Given this list of marker genes Dck, Srsf3, Ifi213, Paqr5, Tpm4, Trim12c, Coro1a, Bcl11a, Phf11b, Sct, Mrfap1, Ifi27l2a, S100a6, Fads3, Samhd1, Isg20, Epsti1, Cbx5, Parp14, Arf4 (NCBI Gene Id 30916), Mvd, Scarb2, Clec2d, Micos10, Slc31a1, Tubb4b, Chordc1, Ifi209, Ptpn6, Bbx, Hck, Exosc3, Ubxn4, Ldlr, Armcx3, Rbm3, Dusp28 (dual specificity phosphatase 28), Tapbpl, Ctsc, Rngtt (RNA guanylyltransferase and 5'-phosphatase), Oasl1, Sec23b, Grn, Tapbp, Mndal, Nt5c3, Ncf1 (neutrophil cytosolic factor 1), Fdft1 (farnesyl diphosphate farnesyl transferase 1), Ly6d, Ifitm3, Nfkbid, Ly86, Ifi47, Bcl7c, Irgm2, Psma5, Nlrc5, Aida, Tor1aip2, Eif1, Or2l13, Msn, Cotl1, H2-T23, Psma7, Phf11a, Nfkbie, Pkib, Cd69, Cyp51, Dnajb1, Tmbim6, Zc3h7a, Lgmn, H2-T22, Ptms, Gramd2b, Calhm6, Helz2, Ssr1, Sgcb, Ppia, Treml2, 9930111J21Rik2, Evi2a, Irf1, Rnh1, Sco1 (NCBI Gene Id 67104), Gbp8, Dclre1c, Pttg1, Tap2, Psma3, Rasa4, Arhgef10l, Hnrnpa3, Parp12 (poly (ADP-ribose) polymerase family, member 12), Prelid3b, Ms4a6c, Glipr1, B2m, Kif5b, Psma4, Bst2, Ifi204 (interferon activated gene 204), Hivep3, Jaml, Galk1 (galactokinase 1), Insig1, Lgals3bp, Psmb9, M6pr, Trafd1, Arf1, Grb2, Spns1, Dynll1, Map2k1, Dnaja1, Plac8, Tmod3, Psme1, Necap2, Sdhb, Sri, Vcpip1, Plaat3, Idi1, Tmsb10, Sp140, Gbp7, Fdps, Pdzd8, Carmil1, Stau2, Ddx60, Pdia3, Hsp90aa1, Plin2, Rell1, Il2rg, Edem1, Eif4g2, Ctsz, Trp53i11, Smim5, Marchf5, Klk1, Hspd1, Mgat1, Psmb6, Npc2, Stip1, Prkcd, Slc35b1, Sla2, Chmp4b, Pml, Nsg2, Ascc3, Nfkb2, Trim30d, Orai3, Etnk1, Cmpk2, Cd52 (NCBI Gene Id 23833), Vdac2, Wdr45b, Gabarap, Dek, Selplg, Tcstv4, Selenow, Slc2a6, Psmb2, Trim30b, Iigp1, Calr, Hsp90b1, Zmiz2, Fnbp4, Procr, Mif4gd, Il21r, Usp18, Sar1a, Gng12, Dynll2, Ifi44, Actr2, Spib, Sec22b, Taldo1, Derl2, Ptges3, Actr3, Srsf5, Gmppb, Ndufa11, Ogfr, Ddx39a, Tmem248, Nampt, Ube2n, Znfx1, Cpne3, Cybc1, Map3k8, Napsa, Nfam1, Sumo1, Anxa4, Nudcd3, Sp100, Zcchc24, Ankrd12, Dnajc3, Oas3, Tor1aip1, Txn1, St13, Manf, Daxx, Esyt1, BC005537, Pmepa1, Pdlim1, Mfsd12 (NCBI Gene Id 73822), Xbp1, Cct3, Xaf1, Klrk1, Zfand3, Ccnd3, Zbp1, Serpina3g, Gtf3c6, Hmgn3, Hspa5, Irf7, Sub1, Emc8, Ndufb6, Psme2, Ergic1, Atp6v1g1, H2-K1, Mpc1, Tlr7, Ccr9, Rftn1, Themis2 (NCBI Gene Id 230787), Ppp1r11, Phyh, Lrp8, Gadd45b, Herc6, Ifit1, Reep3, Isg15, Cacybp, Cpne2, Tagln2, Rac2, Mvp, Cd47, Prdx1, Uba7, Mrpl54, Ifi35, Fbrsl1, H2-Q4, Ly6a, Cdh1, Morc3, Ly6c2, Ifi207 (NCBI Gene Id 98407), Msmo1, Frmd4a, Tcf7l2, Ass1, Parp3, Ly6e, Myo1g, Sell, Slfn8, S1pr4, Rnf213, Stat2, Psma2, Mknk2, Wdr1, Zup1, Kdr, Ube2l6, Mef2a, Adar (adenosine deaminase, RNA-specific), Cdc42, H2-Q6, Cct7, Hnrnpa2b1, Cd164, Trim34a, Rab5c, Mx1, Lrrc59, H2-Q7, Gnb2, Gbp4, Parp9, Atp1b3, Mat2a, Capg (capping actin protein, gelsolin like), Arhgap30 (Rho GTPase activating protein 30), H2-D1 (histocompatibility 2, D region locus 1), Dbnl, Dnajc7, Svbp, Psmd14, Sh3pxd2a, Ptafr, H3f3b, Myl6, Dnajc13, Ifit3, Ube2l3, Slc7a5, Lamp2, Slfn2, Hmgcs1, Slc15a3, Pnp, Eif2ak2, Rsad2, Cib1, Haus8, Tomm70a, Cfl1, Creld2 (cysteine-rich with EGF-like domains 2), Rnf139, Clec9a, Ifi211, Parp11, Oasl2, Vav2, Rap1a, Serinc3, Tpst2, Ms4a4c, Selenos, Ntrk1, Fcer1g, Ctsl, Psmb8, Nmi, Chmp5, Psmb10, Dtx3l, Calm1, Rnase6, Pgap2, Mthfr, Rala, Tmem128, Crlf2, Inpp5b, Creb3, Plaur, Mapkapk2, Pltp, Sdc3, Usp25, Ccnd2, Vim, Shisa5, Tuba1b, Nek6, Tmem63a (transmembrane protein 63a), Tspo (NCBI Gene Id 12257), Trir, Hsph1, Lat, Rigi, Stx16, Tmed7, Gpr162, Ppa1, Ddr1, Arpc5, Tmem219, Ppp1r2, Dhx58, Igtp, Syngr2, Acadl, Scimp, Actg1, Bbip1, Samd9l, Spcs2, Anxa5, Nono, Csrp1 (NCBI Gene Id 98705), Ifih1 (interferon induced with helicase C domain 1), Sec61g, Gna15, Inf2, Ptbp1, Hsp90ab1, Tap1, Apod, Rbm8a, Sp110, Myl12a, Lgals9, Pfkp, Cybb, Txndc5, Oas1a, Irgm1, Igkc, Sqle, Gapdh, Hmgcr, P4ha1, Cd86, Atp2b4, Tspan31, Hspa8, Chchd2, Ifi203, Tpm3, Mpeg1, Sfxn2, Arpp19, Dnajb11, Atp6v1d, Anxa6, Lgals1, Ywhae, Nrros, Pfn1, Iqgap1, Tex2 (testis expressed gene 2), Ifnar1, Ddx24, Cd82, Mycbp2, Slfn5 (schlafen 5), Calm2, Dcaf13, Rnf19b, Reep5, Stat1, Cnn2, Cyba, Ifit2, Arf5, Trim30a, Cycs, Zc3hav1, Trappc3 (NCBI Gene Id 76909), Ccnd1, Casp3 (caspase 3), Phf11d, Cmtm7, Chd4, Tor3a, Serf2, Uso1, Pgam2, Hnrnpab, Cnp, Sdc4 (NCBI Gene Id 99320), Sh3bgr (SH3-binding domain glutamic acid-rich protein), here is a description of the gene set: Mouse Gene Set: CUI_PDC_IFNA1_RESPONSE_UP species: Mus musculus Genes positively differentially expressed in cell type: pDC (plasmacytoid dendritic cell) upon treatment with cytokine: IFN-α1 in mouse lymph nodes in vivo. Cytokines mediate cell-cell communication in the immune system and represent important therapeutic targets. A myriad of studies have highlighted their central role in immune function, yet we lack a global view of the cellular responses of each immune cell type to each cytokine. To address this gap, the authors created the Immune Dictionary, a compendium of single-cell transcriptomic profiles of more than 17 immune cell types in response to each of 86 cytokines (>1,400 cytokine-cell type combinations) in mouse lymph nodes in vivo. A cytokine-centric view of the dictionary revealed that most cytokines induce highly cell-type-specific responses. For example, the inflammatory cytokine interleukin-1β induces distinct gene programmes in almost every cell type. A cell-type-centric view of the dictionary identified more than 66 cytokine-driven cellular polarization states across immune cell types, including previously uncharacterized states such as an interleukin-18-induced polyfunctional natural killer cell state. from publication Cui A, Huang T, Li S, Ma A, Pérez JL, Sander C, Keskin DB, Wu CJ, Fraenkel E, Hacohen N (PMID 38057668)